Given this list of marker genes Slc1a1, Slc1a5, Slc1a6 (solute carrier family 1 (high affinity aspartate/glutamate transporter), member 6), Ucp2, Slc1a3, Slc1a2, Slc1a4, here is a description of the gene set: Mouse Gene Set: GOBP_L_ASPARTATE_TRANSMEMBRANE_TRANSPORT The directed movement of L-aspartate across a membrane by means of some agent such as a transporter or a pore. studied in species Mus musculus